Given this list of marker genes CYB5R1, DHX30 (NCBI Gene Id 22907), GSN, ACYP1, PCM1, PHTF2, RNF141, IKBKE (inhibitor of nuclear factor kappa B kinase subunit epsilon), KMT2A, DNAJB1, C19orf48P, PCCB, HSPE1, RPS4X, ABLIM1, RAB3IP, NSG2, MYC, RCC2, DALRD3, TTC3, KCNN4 (potassium calcium-activated channel subfamily N member 4), TNNT1, DDX47, PELI1, MUC13, CCND2, AMPD3, PAN2, BAD, SMAD7, CD7, NOP56, ITGAE, MAX, ZNF281, HLA-DOB, SELL, RPS3, DNAJC7, MAP7, FNTB, TSR1, RNF38, TP53, IL6ST, DTX1, POLR1B, PRMT3, PDK1, RBM38 (NCBI Gene Id 55544), HDAC2, KCTD12, EVL, NR2C1, RACK1, RFLNB, ITPKB, RPL7L1, HSD17B11, LIPA, RALGPS2, DUSP6, IGF1R, NOMO1, TEC, EPHX1, SKIC2, HAGH, PTOV1, VKORC1, BCKDHB, WFS1, NECAP1, RERE, APEX1, SESN1, CHERP, GRWD1, ACTN1, TTC27, XPC (XPC complex subunit, DNA damage recognition and repair factor), C15orf39, CTSV, NNT, SURF6, SLC12A7, METTL9, CCR7, IGHM, SATB1, NOTCH1, IL4R, VPS37B, P4HA1, SPRED2, RPS19, FKBP4, MAP4K3, IL7R, MTF2 (NCBI Gene Id 22823), MBTD1, USP10, ETS2, RGCC, CAMSAP1, TIMM9, KIT, IFRD2 (interferon related developmental regulator 2), RETREG1, DPH5, MDN1, PKD1, FASN, SIPA1L2, APP, SKI, IL6R, ZNF638, EYA2, TLR6, P2RX4, MFHAS1, CTPS1, MORF4L2, NOLC1 (nucleolar and coiled-body phosphoprotein 1), IDH2, RNASET2, RPS6, SFXN2, C3AR1, RAMP1, CRAMP1, CCR9, NIT2, GNL3, GALNT11, ST6GAL1, CD2AP, SCAMP1, ZNF282, HEXA, MAP1S, SLC11A2, PLEKHA1, WDR6, POU2F1, TBCEL, PRKD2, CXXC5, IPO4, SLC44A1, CLK4, AKAP9, ZNRF1, CDR2, ZMIZ2, HPCAL1, USP34, KANSL2, RPL5, SSBP2, SMAD1, DDC, CTSS, RGS10, RPL6, RPL14, EEIG1, ZNF692, ARRB1, EML5, CRLF3, MRPL23, ZEB1, TCF7, AKR1C4, GADD45A, ADCY6, CNN3, NCOA5, IMP4 (IMP U3 small nucleolar ribonucleoprotein 4), MFN1, MYCBP2, DNAAF10, TDRP, DNAJB2, NEDD4L, PSMG1, SPSB1, DGKA, MPP1, ABCG1, ZBTB20, CASK, ANKRD10, ARMCX2, POLR3A, TCF4, ABCC5, here is a description of the gene set: Genes up-regulated in comparison of naive CD8 T cells versus effector CD8 T cells. CD8 T cells normally differentiate from resting naïve T cells into function effector and then memory CD8 T cells following acute infections. During chronic viral infections, however, virus-specific CD8 T cells often become exhausted. We used microarrays to examine the gene expression differences between naive, effector, memory and exhausted virus-specific CD8 T cells following lymphocytic choriomeningitis virus infection. from publication Wherry EJ, Ha SJ, Kaech SM, Haining WN, Sarkar S, Kalia V, Subramaniam S, Blattman JN, Barber DL, Ahmed R (PMID 17950003) species: Homo sapiens Human Gene Set: GSE9650_NAIVE_VS_EFF_CD8_TCELL_UP